The following is a description of a gene set: studied in species Homo sapiens from publication Schaefer CF, Anthony K, Krupa S, Buchoff J, Day M, Hannay T, Buetow KH (PMID 18832364) Human Gene Set: PID_P38_MKK3_6PATHWAY p38 MAPK signaling pathway, and this is the list of marker genes: TRAF6, MAP3K1, TAB2, GADD45G, TAOK3, TAOK1, GADD45A, TXN (NCBI Gene Id 7295), TRAF2, TAB1, CAMK2B, ATM, MAP3K4, MAP3K3, MAP3K7, MAPK14, MAP3K10, MAP3K5, MAP2K6, MAPK11, GADD45B, RAC1, MAP2K3, TAOK2, CCM2, MAP3K6